The following is a description of a gene set: Marker genes down-regulated in the 'chromosome 7 polysomy' subclass of hepatocellular carcinoma (HCC); characterized by polysomy of chromosome 7 and by a lack of gains of chromosome 8q. species: Homo sapiens Hepatocellular carcinomas represent the third leading cause of cancer-related deaths worldwide. The vast majority of cases arise in the context of chronic liver injury due to hepatitis B virus or hepatitis C virus infection. To identify genetic mechanisms of hepatocarcinogenesis, we characterized copy number alterations and gene expression profiles from the same set of tumors associated with hepatitis C virus. Most tumors harbored 1q gain, 8q gain, or 8p loss, with occasional alterations in 13 additional chromosome arms. In addition to amplifications at 11q13 in 6 of 103 tumors, 4 tumors harbored focal gains at 6p21 incorporating vascular endothelial growth factor A (VEGFA). Fluorescence in situ hybridization on an independent validation set of 210 tumors found 6p21 high-level gains in 14 tumors, as well as 2 tumors with 6p21 amplifications. Strikingly, this locus overlapped with copy gains in 4 of 371 lung adenocarcinomas. Overexpression of VEGFA via 6p21 gain in hepatocellular carcinomas suggested a novel, non-cell-autonomous mechanism of oncogene activation. Hierarchical clustering of gene expression among 91 of these tumors identified five classes, including CTNNB1, proliferation, IFN-related, a novel class defined by polysomy of chromosome 7, and an unannotated class. These class labels were further supported by molecular data; mutations in CTNNB1 were enriched in the CTNNB1 class, whereas insulin-like growth factor I receptor and RPS6 phosphorylation were enriched in the proliferation class. The enrichment of signaling pathway alterations in gene expression classes provides insights on hepatocellular carcinoma pathogenesis. Furthermore, the prevalence of VEGFA high-level gains in multiple tumor types suggests indications for clinical trials of antiangiogenic therapies. Human Gene Set: CHIANG_LIVER_CANCER_SUBCLASS_POLYSOMY7_DN from publication Chiang DY, Villanueva A, Hoshida Y, Peix J, Newell P, Minguez B, LeBlanc AC, Donovan DJ, Thung SN, Solé M, Tovar V, Alsinet C, Ramos AH, Barretina J, Roayaie S, Schwartz M, Waxman S, Bruix J, Mazzaferro V, Ligon AH, Najfeld V, Friedman SL, Sellers WR, Meyerson M, Llovet JM (PMID 18701503), and this is the list of marker genes: GNL3, STOX2, AACS, PLOD2, KLB, CERS6, RHOBTB1, P2RX5, SLC38A1, ASAP1, RBIS, FAM171A1, BAMBI, RCN1, SERPINB1, DRAM1, CARD6, HOMER1, PHACTR2, AKR1B10, PAG1, SLC16A7, MOB1B, GPX2, ROBO1